The following is a description of a gene set: Genes up-regulated in comparison of dendritic cells (DC) stimulated with R848 at 2 h versus DCs stimulatd with R848 for 8 h. Human Gene Set: GSE2706_2H_VS_8H_R848_STIM_DC_UP from publication Napolitani G, Rinaldi A, Bertoni F, Sallusto F, Lanzavecchia A (PMID 15995707) Toll like receptors (TLRs) sense microbial products and initiate adaptive immune responses by activating dendritic cells (DCs). Since pathogens may contain several agonists we asked whether different TLRs may synergize in DC activation. We report that in human and mouse DC TLR3 or TLR4 potently synergize with TLR7, TLR8 or TLR9 in the induction of selected cytokine genes. Upon synergistic stimulation, IL-12, IL-23 and Delta-4 are induced at levels 50-100 fold higher than those induced by optimal concentrations of single agonists, leading to enhanced and sustained TH1 polarizing capacity. Using microarray analysis we show that only 1.5% of the transcripts induced by single TLR agonists are synergistically regulated by combinations of TLR4 and TLR8 agonists. These results identify a combinatorial code by which DCs discriminate pathogens and provide (suggest) a rationale to design adjuvants for TH1 responses. Series_overall_design: 3 untreated, 3 treated with LPS at 2h, 3 treated with LPS at 8h, 3 treated with R848 at 2h, 3 treated with R848 at 8h, 3 treated with LPS + R848 at 2h, 3 treated with LPS + R848 at 8h studied in species Homo sapiens, and this is the list of marker genes: ZNF503, DPY19L1, SPATA2, CTSC, TMEM165, TMEM91, TJP2, BLVRB, SIVA1, ARHGEF10L, RNF130 (ring finger protein 130), TREM2, MAP4K1, BTBD2, SLC38A6, AGTRAP, RPL39L, DCUN1D3, NUDT10, MFSD12, IER3, POLR2E, SLC41A3, SPATA3-AS1, PTGS1, AHCY, DERL3, FDXR, ICAM2, MPST, EPHX1, SIGIRR, TPCN1, C1RL, F8, CELF1, HLA-DMB, NAPRT, PINK1, TRMT5 (NCBI Gene Id 57570), GPR108, MAFF, MAP2K3, NMNAT3 (NCBI Gene Id 349565), SNRNP25, PRC1, PYGL, RBM46, RAP2C, TIFA, PLXDC2, CBX7, TECR, MPP1, ERBIN, PIGK, ALDH3A2, SLC25A48, KIAA0513, TRIM47, PLEK, SIGLEC17P, TGFB1I1, ATP2A3 (NCBI Gene Id 489), ASGR2, AHRR, MEAK7, SLC2A3, TMEM154, RSPH1, FOXRED1, RAB3IP, KDM6B, TMEM88, GRAMD2B, BTG2, NFIA, SLC19A1, BAD, PECAM1, SPTBN1, DUOX1, YIF1B, ACP5, MS4A6A, CHID1, CYP1B1, RILPL2, WDR35, NRGN, DPEP2, ZNF697, CDA, DOCK3, PLPP3, MAN2B2, DHRS1, CCRL2, CRISPLD2, MAP3K5, LINC02297, SLC12A1, LPCAT1, ACY1, HEXA, ACADSB, CRYL1, POLR2J2, ICAM1, CDC42EP2, PTGER2 (prostaglandin E receptor 2), BACE1, FAM210B, SGK1, LPCAT4, MIR3142HG, MGMT (NCBI Gene Id 4255), CNBD2, SH3BGR, ABAT, FES, P2RY11, SLC66A3, ASB17, PDK3, LINC00528, PLAU, ATP8A1, GNA12, EGR3, RASSF5, QSOX1, DCXR, SLC22A18, BAIAP2-DT, SORT1 (sortilin 1), FXYD5, CRAT, SCARB1, ANKH, IQCK, P2RX1, TREML1, GEM, ALDH5A1, ZCCHC24 (zinc finger CCHC-type containing 24), IL25, NPC2, F3, MGC16275, ABHD14A, RARG, PLBD1, ESYT1, ABCG1, DCN, FCER2, PRAM1, NFE2L2, DENND3, TMEM205, SGMS2, TBXAS1, RBP4, GFRA2, GLRX, CYB5D1, ATP6V0E2, MAML3, SCRN2, IL18BP, ADNP2, HCAR3, ADISSP, CFAP36, CRACR2B, VPS37B, PRKACB, CSF3R, NCSTN, TRPV6, FOXO3, LY9, CRTAP, SLC16A6, TGFBI, HVCN1, TIMP2, KLHL40, EGR1, SDC4, SQSTM1, PHF19, ADAM15